The following is a description of a gene set: studied in species Homo sapiens Tumor growth is associated with a profound alteration of myelopoiesis, leading to recruitment of immunosuppressive cells known as myeloid-derived suppressor cells (MDSCs). Analyzing the cytokines affecting myelo-monocytic differentiation produced by various experimental tumors, we found that GM-CSF, G-CSF, and IL-6 allowed a rapid generation of MDSCs from precursors present in mouse and human bone marrow (BM). BM-MDSCs induced by GM-CSF+IL-6 possessed the highest tolerogenic activity, as revealed by the ability to impair the priming of IFN- -producing CD8+ T cells upon in vivo adoptive transfer. Moreover, adoptive transfer of syngeneic, GM-CSF+IL-6-conditioned MDSCs to diabetic mice transplanted with allogeneic pancreatic islets resulted in long term acceptance of the allograft and correction of the diabetic status. Cytokines inducing MDSCs acted on a common molecular pathway. Immunoregulatory activity of both tumor-induced and BM-derived MDSCs was entirely dependent on C/EBP transcription factor, a key component of the emergency myelopoiesis triggered by stress and inflammation. Adoptive transfer of tumor antigen-specific CD8+ T lymphocytes resulted in therapy of established tumors only in mice lacking C/EBP in myeloid compartment. These data unveil another link between inflammation and cancer and identify a novel molecular target to control tumor-induced immune suppression. We used gene expression analysis to identify those factors, secreted by tumor-infiltrating MDSC, which could drive emathopoiesis. Moreover we compare gene expression profile of tumor-induced MDSC, obtained from either the spleen and the tumor infiltrate of tumor bearing mice, and in vitro bone marrow-derived MDSC. Genes down-regulated in CD11b Spleen from C57BL6 mouse versus CD11b Tumor from C57BL6 mouse. Human Gene Set: GSE21927_SPLEEN_VS_TUMOR_MONOCYTE_C57BL6_DN from publication Marigo I, Bosio E, Solito S, Mesa C, Fernandez A, Dolcetti L, Ugel S, Sonda N, Bicciato S, Falisi E, Calabrese F, Basso G, Zanovello P, Cozzi E, Mandruzzato S, Bronte V (PMID 20605485), and this is the list of marker genes: BIVM, LRCH2, HAGHL, ADARB1, PPP6R3, ZNF271P (NCBI Gene Id 58502), LGALS8, CAT, SGTB, FNDC3A, TIAM1 (TIAM Rac1 associated GEF 1), CAPRIN1, CLCN2, INO80D, ACTG1, HRK, LSM14A, TARBP1, SLC1A1, BAIAP2L1, MND1, TBX6, MME, GPATCH2L (NCBI Gene Id 82392), C2orf15, NXF5, AASS, TM2D1, EMB, HEATR3, CFC1B, TTC13, RPPH1, C11orf65, MARCHF11-DT, LINC01704, ZNF556, NEK3, NNT, ZNF230, ST3GAL2, VPS37A, AGAP1, EPS15, MPPED2, CCDC102A, CCDC85C, NPM3, SIRPB2, NLGN3, DCLRE1C, ACSBG2, TCF24, ATPAF1, TPD52, CORO2B (NCBI Gene Id 10391), SMG1P5, HTATSF1P2, CMA1, UBXN7, IRGQ, RPGR, NPY4R, RCN3, ENKD1, RAB14, DCAF12, TRIM49, TPSB2, MUC5B, PHTF2, AKAP8, BASP1-AS1, ARRDC4, SLC35F5, PLEKHA7, NAP1L3, BAZ2B, PAXIP1, ZMYM5, GOLPH3, SLC16A7, PHGR1, RBM28, SLC7A6, ENSG00000240207, USP46, CACNA1I, MTUS2, CDKN2B-AS1, SH3BP4, CNGA3, KCNQ4, IFT52, MCF2L2, LMLN, ZCCHC13, PIK3C2B, SEPTIN2, PLEKHA3, AMFR, PARD6G, NLRP7, CFHR3, PTBP2, RHBDF1, RASGRP4, RIMBP2, SP140, CLYBL (NCBI Gene Id 171425), GSTA4, USP4, SPMIP10, FOXD2-AS1, LINC00466, ALDH1A2, CLINT1, SHC1, DIO3, PCDHB9, AK4, RACGAP1P1, ITGA9, RYR1, FOXP1-IT1, DBNL, WEE2-AS1, ZNF34, RASSF6, NAF1 (NCBI Gene Id 92345), TUBGCP5, PARP10, IFT20, IGSF11-AS1, PKIB, NAV1, ADGRG6, PPP1R15B, MARCHF11, GSTCD, STT3B, TET3, GAS2L2, FBXO30, FAM200C, MDFI, GAS2L1, KIF26B, CPNE8, CYTH3, KNOP1, CCDC190, LINC01785 (NCBI Gene Id 374890), PAGE5, ARHGAP26, STAG3L4, UNC119B, EPB41L5 (NCBI Gene Id 80242), PALS1 (NCBI Gene Id 64398), SPG21, C6orf118, TMEM128, GPRC5D, H1-3, PDHB, SERTAD2, NUP107, RLN2, PPA1, PYROXD1, QRICH2, NLRP10, DNAJC1, CD38, DYNC1LI2, CHD1L, PCDHGA4, ATL1, HCFC2, KMT2C, PNPLA1, RNF4, NOS3, SUCLA2 (succinate-CoA ligase ADP-forming subunit beta), ZNF677, RPS16P5, BMS1P20, TASOR2 (NCBI Gene Id 54906), SOX12